The following is a description of a gene set: Human Gene Set: HP_PARATHYROID_CARCINOMA A malignancy of the parathyroid glands. Parathyroid carcinoma usually secretes parathyroid hormone, leading to hyperparathyroidism. species: Homo sapiens Parathyroid carcinoma, and this is the list of marker genes: CDKN1B, CDKN2C, CDC73, CDKN2B, CDKN1A, GCM2, MEN1